The following is a description of a gene set: Mouse Gene Set: GOMF_CALCIUM_CHANNEL_REGULATOR_ACTIVITY species: Mus musculus Modulates the activity of a calcium channel., and this is the list of marker genes: Grm7, Cacng8, Slc30a1, Phpt1, Prkg1, Stim2, Prkcb, Hpcal4, Calm1, Cav3, Ywhae, Cacnb3, Fkbp1b, Tspan13, Nrxn2, Cacnb2, Nrxn3, Crisp4, Gnb2, Stim1, Cacng7, Calm3, Tnni3 (NCBI Gene Id 21954), Grm3, Rem1, Cabp4, Grm2, Pde4d (phosphodiesterase 4D, cAMP specific), Stx1a, Micu1, Cacng1, Cacng4, Rasa3 (NCBI Gene Id 97473), Itpr1, Rrad, Gem, Cacng6, Rem2, Micu2, Cabp1, Nrxn1, Mcub, Calm2, Micu3, Stimate, Pacsin3, Cabp2, Cabp5